Given this list of marker genes DHX36, POT1, WRN, LONP1, PIF1, XRN1, NME2, CNBP, BLM, DDX11, RAD50, here is a description of the gene set: Binding to G-quadruplex DNA structures, in which groups of four guanines adopt a flat, cyclic Hoogsteen hydrogen-bonding arrangement known as a guanine tetrad. The stacking of guanine tetrads results in G-quadruplex DNA structures. G-quadruplex DNA can form under physiological conditions from some G-rich sequences, such as those found in telomeres, immunoglobulin switch regions, gene promoters, fragile X repeats, and the dimerization domain in the human immunodeficiency virus (HIV) genome. studied in species Homo sapiens Human Gene Set: GOMF_G_QUADRUPLEX_DNA_BINDING